Given this list of marker genes H2BC14, RNF144A, SHPRH, H2BC15, UBE2L3, UBE2J2, UBE2Q2, PEX14, SKIC8, PAF1, UBE2S, RNF181, VCP, HLTF, RRAGA, PEX12, LEO1, PEX5, UBE2V2, UBE2K, UBE2B, H2BC9, H2BC13, PEX10, UBB, UBE2R2, USP5, USP7, RAD18, PEX13, HLA-B, PCNA (NCBI Gene Id 5111), CDC73, UBE2C, H2BC1 (NCBI Gene Id 255626), RPS27A, PEX2, UBE2N, UBC, DERL1, UBE2A, RTF1, H2BC17, H2BC4, CTR9, UBE2D1, UBE2E1, UBE2E3, PRKDC, UBE2G1, UBA6, H2BC5, BCL10, SELENOS (NCBI Gene Id 55829), UBE2T, RNF152, HLA-A, WAC, TMEM129, UBE2D3, USP9X, UBE2Z, UBA52, US11, RNF40, OTULIN, H2BC12, UBE2D2, UBE2W, UCHL3, CDC34, UBE2G2, H2BC11, UBA1, UBE2H, RNF20, H2BC3, here is a description of the gene set: Ubiquitin is a small, 76 amino acid residue protein that is conjugated by E3 ubiquitin ligases to other proteins in order to regulate their function or degradation (enzymatic cascade reviewed in Neutzner and Neutzner 2012, Kleiger and Mayor 2014, structures and mechanisms of conjugating enzymes reviewed in Lorenz et al. 2013). Ubiquitination of target proteins usually occurs between the C-terminal glycine residue of ubiquitin and a lysine residue of the target, although linkages with cysteine, serine, and threonine residues are also observed.<br>Ubiquitin must first be processed from larger precursors and then activated by formation of a thiol ester bond between ubiquitin and an E1 activating enzyme (UBA1 or UBA6) and transfer to an E2 conjugating enzyme before being transferred by an E3 ligase to a target protein. Precursor proteins containing multiple ubiquitin monomers (polyubiquitins) are produced from the UBB and UBC genes; precursors containing a single ubiquitin monomer and a ribosomal protein are produced from the UBA52 and RPS27A genes. Many proteases (deubiquitinases) may potentially process these precursors yielding monomeric ubiquitin. The proteases OTULIN and USP5 are particularly active in cleaving the polyubiquitin precursors, whereas the proteases UCHL3, USP7, and USP9X cleave the ubiquitin-ribosomal protein precursors yielding ubiquitin monomers. A resultant ubiquitin monomer is activated by adenylation of the C-terminal glycine followed by conjugation of the C-terminus to a cysteine residue of the E1 enzymes UBA1 or UBA6 via a thiol ester bond. The ubiquitin is then transferred from the E1 enzyme to a cysteine residue of one of several E2 enzymes. Through a less well characterized mechanism, E3 ubiquitin ligases then bring a target protein and the E2-ubiquitin conjugate into proximity so that the ubiquitin is transferred via formation of an amide bond to a particular lysine residue (or, in rarer cases, a thiol ester bond to a cysteine residue or an ester bond to a serine or threonine residue) of the target protein. Based on protein homologies, families of E3 ubiquitin ligases have been identified that include RING-type ligases, HECT-type ligases, and RBR-type ligases. A subset of the RING-type ligases participate in CULLIN-RING ligase complexes (CRLs which include SCF complexes, reviewed in Lee and Zhou 2007, Genschik et al. 2013, Skaar et al. 2013, Lee et al. 2014).<br>Some E3-E2 combinations catalyze mono-ubiquitination of the target protein. Other E3-E2 combinations catalyze conjugation of further ubiquitin monomers to the initial ubiquitin, forming polyubiquitin chains. (It may also be possible for some E3-E2 combinations to preassemble polyubiquitin and transfer it as a unit to the target protein.) Ubiquitin contains several lysine (K) residues and a free alpha amino group to which further ubiquitin can be conjugated. Thus different types of polyubiquitin are possible: K11 linked polyubiquitin is observed in endoplasmic reticulum-associated degradation (ERAD), K29 linked polyubiquitin is observed in lysosomal degradation, K48 linked polyubiquitin directs target proteins to the proteasome for degradation, whereas K63 linked polyubiquitin generally acts as a scaffold to recruit other proteins in several cellular processes, notably DNA repair. Ubiquitination is highly regulated and affects all cellular processes including DNA damage response, immune signaling, and regulation of normal and cancerous cell growth. part of: Post-translational protein modification Reactome Pathway: Protein ubiquitination species: Homo sapiens